Given this list of marker genes MYD88, ABR, ARHGEF12, FGD2, ARHGEF4, ECT2, CASP2, PRDM4, NGFR, PLEKHG5, PLEKHG2, NFKB1, TRIO, UBC, RPS27A, MCF2, ARHGEF5, ARHGDIA, ARHGEF40, GNA13, IRAK1, AKAP13, ARHGEF17, ARHGEF38, NFKBIA (NCBI Gene Id 4792), VAV1, VAV2, NGF, TIAM2 (NCBI Gene Id 340133), ARHGEF11, RIPK2, SQSTM1, PREX1, ITGB3BP, FGD3, BAD, ARHGEF7, BEX3, ITSN1, VAV3, FGD4, ARHGEF26, ARHGEF2, NCSTN, FGD1, KALRN, ARHGEF39, RASGRF2, APH1B, ARHGEF33, NGEF, NET1, TIAM1, ARHGEF35, ARHGEF1, ARHGEF18, TRAF6, SOS2, HDAC2, UBB, PSEN2, ARHGEF37, ADAM17, YWHAE, PSENEN, LINGO1, OBSCN, ARHGEF10, ARHGEF6, OMG, HDAC3, BCL2L11, MAPK8, HDAC1, MAG, RHOA, MCF2L, RTN4R, ARHGEF3, MAGED1, PRKCI, RELA, UBA52, RAC1, ARHGEF19, RTN4, SMPD2, AATF, ARHGEF16 (Rho guanine nucleotide exchange factor 16), SOS1, APH1A, ARHGEF10L, PSEN1 (presenilin 1), IKBKB, CASP3, ARHGEF15, ARHGEF9, here is a description of the gene set: species: Homo sapiens p75 NTR receptor-mediated signalling Human Gene Set: REACTOME_P75_NTR_RECEPTOR_MEDIATED_SIGNALLING